The following is a description of a gene set: studied in species Mus musculus Mouse Gene Set: WP_MITOCHONDRIAL_LONG_CHAIN_FATTY_ACID_BETAOXIDATION Mitochondrial long chain fatty acid beta-oxidation, and this is the list of marker genes: Scp2, Eci1, Acadm (acyl-Coenzyme A dehydrogenase, medium chain), Acsl3, Slc25a20, Cpt1a, Acadvl, Hadh, Pecr, Acsl4, Acsl1, Ehhadh, Acadl, Cpt2, Hadha, Acads